The following is a description of a gene set: studied in species Homo sapiens Tubular luminal dilatation Dilatation (expansion beyond the normal dimension) of the cavity (lumen) of tubules of the kidney. The tubular cross section displays an attenuated brush border (apical PAS positivity greater than 10 percent of the normal expected height, but unequivocally less than normal expected height), resulting in an apparent increase in the size of lumen. Human Gene Set: HP_TUBULAR_LUMINAL_DILATATION, and this is the list of marker genes: TULP3, SLC41A1, CRB2, TMEM67, DCDC2